The following is a description of a gene set: Human Gene Set: WP_TGFB_SMAD_SIGNALING studied in species Homo sapiens TGFB / Smad signaling, and this is the list of marker genes: TGFBR1, WWTR1, SPARC, TGFBR2, CCN2, POSTN, TGFBR3, SMAD2 (NCBI Gene Id 654050), SMAD3, YWHAG, SERPINE1, SMAD4